Given this list of marker genes Alox15, Gpx4, Alox5 (arachidonate 5-lipoxygenase), Ptgs2, Lta4h, Hpgd, here is a description of the gene set: species: Mus musculus Biosynthesis of EPA-derived SPMs Mouse Gene Set: REACTOME_BIOSYNTHESIS_OF_EPA_DERIVED_SPMS